Given this list of marker genes TJP2, DHX58, IL18RAP, LYPD1, PI4K2B, TTYH2, SLC1A2, DDX60L, CLEC2D, MAP3K8, BCL2A1, TENT4A, ENSG00000271776, GPR132, CCNA1, PRKD1 (NCBI Gene Id 5587), SORCS1, FBLN5, IDO2, GJB2, HERC5, IFNB1, LRRC3, ZC3H12C, CNKSR3, HESX1, CALCR, RASGRP1, APOL1, USP12, HOXD10, IL19, CCL5, NLRC5, PSD3, STK26, PSG5, KRTAP9-8, GNGT1, RETREG1, PTGER4, ARHGAP22, BCL2L14, TMEM268, IL4I1, ABTB2, BHLHE22, RASGEF1B, C21orf91, RNF213 (ring finger protein 213), KRT76, RNF186, CPNE8, MAGEA6, PLAGL2, EXPH5, PTGS2, ARMCX1, BRIP1, CRPPA-AS1, RIGI, SLC6A15, RPS6KL1, TNC, KANK1, LINC02171, AVP, BAG3, KLF7, SKIL, C4orf46, CPLX1 (complexin 1), ZBTB10, NFKB1, IL6 (interleukin 6), ZBTB43, OGDHL, ADORA2A, CEACAM5, GBP5, LIFR, PIK3R3, UPB1, CHADL, DENND5A, IFT56 (intraflagellar transport 56), TAAR1, DGCR5, LINC01619, LINC01600, CELA1, NCF1C, ACSL1, NRP2, TNFSF15, TNFSF9, TTN, BEND2, PARPBP, NPNT, GJA1, MELK, OASL, OXTR, CARD11, BAMBI, ERFE, NECTIN3, IFNL1, MFHAS1, CXCL8, STAT4 (NCBI Gene Id 6775), MIR3945HG, SCN8A, SAMD9L, GZMK, DUSP1, RPA4, GUCY1A1, LSS, KIAA1549, ACTA1, ADAMTSL5, GARIN5B, IL1A, TNFAIP6, IRAK2, STX11, NUB1, FBXL19-AS1, LINC01968, PUS10, GEM, ZBP1, NR4A3 (NCBI Gene Id 8013, nuclear receptor subfamily 4 group A member 3), CLDN3, EN1, DNASE1L2, MIR155HG, ERRFI1, GALNT3, LYSMD2, KLC3 (NCBI Gene Id 8185), IRF1, MUSTN1, PIWIL4, LILRA5, PRX, IL15RA, AIM2, MIXL1, PHF21B (NCBI Gene Id 50609), GCH1, SP2-AS1, ZHX2, USP18, SNN, DRAM1, TNFAIP2, GSG1, ZC3HAV1, PTPRF, CEMIP, RD3, ADAM18, ADORA2A-AS1, DNAAF1, USP42, PELI1, EPHA5, ARAP2, THAP3 (THAP domain containing 3), MCOLN2, RAPGEF2, ANKRD33B, ZNF536, SMIM10L2B-AS1, FRMD7, CXCL3, NAMPT (NCBI Gene Id 10135), FAM9B, RIPK1, CYP7B1, EREG, MT1HL1, TRIP10, MARCKS (myristoylated alanine rich protein kinase C substrate), LRATD1, GPR84, SASH1, LATS2, FUT4, ABCA3, PALMD, HS3ST3B1, here is a description of the gene set: Genes up-regulated in CD8 T effectors at acute infection with LCMV-Armstrong: day 6 versus day 15. from publication Doering TA, Crawford A, Angelosanto JM, Paley MA, Ziegler CG, Wherry EJ (PMID 23159438) Human Gene Set: GSE41867_DAY6_VS_DAY15_LCMV_ARMSTRONG_EFFECTOR_CD8_TCELL_UP studied in species Homo sapiens During acute viral infections, naïve CD8+ T cells differentiate into effector CD8+ T cells and, after viral control, into memory CD8+ T cells. Memory CD8+ T cells are highly functional, proliferate rapidly upon reinfection and persist long-term without antigen. In contrast, during chronic infections, CD8+ T cells become “exhausted” and have poor effector function, express multiple inhibitory receptors, possess low proliferative capacity, and cannot persist without antigen. To compare the development of functional memory T cells with poorly functional exhausted T cells, we generated longitudinal transcriptional profiles for each.